The following is a description of a gene set: Human Gene Set: GOBP_INTRA_GOLGI_VESICLE_MEDIATED_TRANSPORT The directed movement of substances within the Golgi, mediated by small transport vesicles. These either fuse with the cis-Golgi or with each other to form the membrane stacks known as the cis-Golgi reticulum (network). species: Homo sapiens, and this is the list of marker genes: NAPA, COPB2, COPE, RAB6A, RAB6D, GABARAPL2, COG3, TRAPPC10, COG8, GOSR1, COPZ1, RAB33B, COPZ2, COG7, VTI1B, NAPG, RAB41, GOLGA5, GOSR2, RAB6C (NCBI Gene Id 84084), COG4, COPG1, COPB1, TRAPPC3, RAB6B, NSF, COG6, COPG2, COG1, TRAPPC3L, COG5, VTI1A, COPA (COPI coat complex subunit alpha), CUX1, COG2